Given this list of marker genes LMTK3, TNNT3, ANKS6, AGR3, IFI6, DUS1L, CLDN1, SPIRE2, LPAR6, LYN, KRT5, SEZ6L2, MESP1, STEAP4, CAPS, PSMB10, RGS10, FBN1, TNFRSF14, ANXA1, BST1, PDE8A, SPINK5, BSPRY, AMOT, N4BP3, ATP13A4, COG8, NXPH4, PHLDB3, NDUFA4L2, A4GALT, LOXL1-AS1, UPK1B, ANKRD18A, TMEM184A, GRHL1, RND3, DNAJA4, PGM2L1, PRR15, ASS1, VSIR, PAQR4, SLC39A11, SYTL2, GTPBP2, CEACAM6, TRIM29, FUT3, PLEKHG5, HCAR3, LCN2, VCAN, GNA15, PLEKHM1, EDN1, CAPNS2, CXCL6, NECTIN1, PITPNM1, HTATIP2, SLC1A5, KLK11, ATP12A, MX1, TSPAN5, ERMP1, TNFAIP2, KSR1, CLDN10, PAX9, ISG20 (NCBI Gene Id 3669), PLAAT3, KRT7, MCM8, GLIPR2, SLC44A4, IL32, CLUH, SMIM31, LRRC4 (leucine rich repeat containing 4), PRADC1, OPTN, SLFN5, CD82, MPZL3, KRT6B, HCAR2, SLPI, ANKRD35, EYA2, WIPI1, SOD3, IGFBP4, CASZ1, MUC4, SLC31A1, CCDC122, FAM3D (NCBI Gene Id 131177), FUOM, ST6GALNAC1, GABRP, BORCS8, MYB, EHD2, SCGB3A1 (secretoglobin family 3A member 1), TNFSF10 (NCBI Gene Id 8743), PROM1, LINC01133, TONSL (NCBI Gene Id 4796), XKRX, CAMK1D, SULT2B1, TSPAN1, EPAS1, RAI1, MUC20, SFN, EPB41L4B, VTCN1, FUT2, CYP2F1 (cytochrome P450 family 2 subfamily F member 1), ARAP2, SIX1, KDM7A, SCGB1A1, DGKA, SLC15A2, MUC15, NUDT8, S100A2, CCNO, HEY2, ARHGAP32, TNFAIP8 (TNF alpha induced protein 8), CFH, BICDL2 (BICD family like cargo adaptor 2), MSLN, ITGB8, TM4SF1, MEG8, SLCO3A1, CKMT1B, HLA-B, NEBL, BIK, SNTB1, TFAP2A, MEG3, SEMA3F, KRT4, PRKCH, ITGB4, S100A9, IGFBP3, CASC2, TLR5, LGR4, S100P, PKP1, UBD, SREBF1, CSTA, PRRG4, KIF26B, HS3ST1, ALDH1A3, EHF, OSCP1, CH25H, LIPH, SGPP2, MPDU1-AS1 (MPDU1 antisense RNA 1), B3GNT3, GLIS3, CCL20 (C-C motif chemokine ligand 20), PART1, ALPL, VAMP5, PLAAT4, SLCO4C1, C15orf62, LYPD6B, STXBP6, BHLHE40, CFLAR, NPDC1, TBC1D30, C15orf48, TSHZ2, KRT15, CYP2J2, ETV3, FBLN2, GRHL3, TRMT2B, NUPR1, MUC16, PFKP, SMIM5, CPAMD8, CDR2L (NCBI Gene Id 30850), KLHL5, CFAP263, CDKN1A, SERPINB2, GRAMD2B, C3, FXYD5, SAMHD1, ABO, KCNK6, BBOF1, LGALS9, TMEM40, PLAC8, LSP1, MAP3K6, CHST9, IFITM1, RHOV, ADGRF1, KIAA1671, MAFB, CXCL1, here is a description of the gene set: species: Homo sapiens Proximal secretory 3 Human Gene Set: HE_LIM_SUN_FETAL_LUNG_C1_PROXIMAL_SECRETORY_3_CELL from publication He P, Lim K, Sun D, Pett JP, Jeng Q, Polanski K, Dong Z, Bolt L, Richardson L, Mamanova L, Dabrowska M, Wilbrey-Clark A, Madissoon E, Tuong ZK, Dann E, Suo C, Goh I, Yoshida M, Nikolić MZ, Janes SM, He X, Barker RA, Teichmann SA, Marioni JC, Meyer KB, Rawlins EL (PMID 36493756)